Given this list of marker genes TAGLN, GAS1, NCAM1, ANKRD1, PLAGL1, ASS1, ADAM19, SERPINF1, KRT19, CNN1, NQO1, CXCL10, GREM2, FAM43A, ACTA2, ELMO1, SPP1, here is a description of the gene set: species: Mus musculus Genes down-regulated in MEF cells (embryonic fibroblasts) by overexpression of HOXC8. Human Gene Set: LEI_HOXC8_TARGETS_DN Hox genes encode transcription factors that control spatial patterning during embryogenesis. To date, downstream targets of Hox genes have proven difficult to identify. Here, we describe studies designed to identify target genes under the control of the murine transcription factor Hoxc8. We used a mouse 16,463 gene oligonucleotide microarray to identify mRNAs whose expression was altered by the overexpression of Hoxc8 in C57BL/6J mouse embryo fibroblasts (MEF) in cell culture (in vitro). We identified a total of genes whose expression was changed by 2-fold or greater: genes were up-regulated, and genes were down-regulated. The majority of genes encoded proteins involved in critical biological processes, such as cell adhesion, migration, metabolism, apoptosis, and tumorigenesis. Two genes showed high levels of regulation: (i) secreted phosphoprotein 1 (Spp1), also known as osteopontin (OPN), was down-regulated 4.8-fold, and (ii) frizzled homolog 2 (Drosophila) (Fzd2) was up-regulated 4.4-fold. Chromatin immunoprecipitation (ChIP) analysis confirmed the direct interaction between the OPN promoter and Hoxc8 protein in vivo, supporting the view that OPN is a direct transcriptional target of Hoxc8. from publication Lei H, Wang H, Juan AH, Ruddle FH (PMID 15699330)